The following is a description of a gene set: Human Gene Set: HP_ABNORMAL_THIRD_TOE_MORPHOLOGY species: Homo sapiens Abnormal third toe morphology An anomaly of the third toe., and this is the list of marker genes: BCOR, NOG, SALL1, EOGT, MAP3K20, LMNA, DACT1, TBX5, COG8, TBC1D2B